The following is a description of a gene set: species: Homo sapiens from publication Zhong S, Zhang S, Fan X, Wu Q, Yan L, Dong J, Zhang H, Li L, Sun L, Pan N, Xu X, Tang F, Zhang J, Qiao J, Wang X (PMID 29539641) Human Gene Set: ZHONG_PFC_C2_THY1_POS_OPC, and this is the list of marker genes: S100B, PCSK1N, GRB14, SERTAD4BP, ELMO1, FAM216A, SCG5, LRRK2, PMP2, PLAT, GPR155, LAMA4, SULF2, MYT1, BRINP1, ITM2A, KLRC2, EDNRB, WAC-AS1, CNTN1, APOD, THY1, CA10, NTNG1, PLLP, COL9A1, SNTG1